Given this list of marker genes MEGF10, RHOA, HAVCR1, GATA2 (NCBI Gene Id 84724), ELMO1, DOCK1, ADGRB1, TREM2, FCGR1A, SMURF1, ARHGAP25, CHMP4A, STAP1, MYH9, ARF1, BECN1, ITGB2, CLCN3, FCER1G, ALKBH4, NCKAP1L, GULP1, THBS1, XKR6, CD300A, SPIRE1, ARHGAP12, C3, VAMP7, XKR7, HGS, ITGA2, BIN2, RAC1, ABCA7, SPIRE2, CHMP2A, MARCO, FNBP1L (formin binding protein 1 like), XKR8, CLCN2, PLCG2, APPL2, ABCA1, ALOX15, SNX3, MSR1, ITGAM, XKR4, TIMD4, FCGR2B, AURKB, SNX33, SNX18, GSN, CD36, F2RL1, ANO6, CDC42, SNX9, SH3BP1, RAB31, FCHO2, AIF1, here is a description of the gene set: studied in species Homo sapiens Human Gene Set: GOBP_MEMBRANE_INVAGINATION The infolding of a membrane.